Given this list of marker genes SCAI, HCAR1, G6PC2, ZNF417, CALM2, THAP2, FAM151B, MOSPD3, HAPLN1, CHP1, EGF, ZDHHC17, SSBP1, USF3, CAPN6, TIMP3, GAP43, TBL1XR1, UBE2W, AAK1, TSHZ2, SERTAD2, TMEM170B, SAMD12, RAB3GAP2, DGKI, ALG10 (ALG10 alpha-1,2-glucosyltransferase), DGKH, NFX1, URI1, MBTD1, FAM168A, GALNT10, SESTD1, CCDC34 (NCBI Gene Id 91057), HLCS, USP33, MAP2K1, CLVS1, JADE1, HACD1, TCF7L2, FCGR3B, ZC3H6, RGL1, YWHAQ, HMGN3, CCDC85C, GSPT1, LAMA4, FAM221A, KDM7A, GYS2, FRMD6, BBS10, PROK2, HCN3, CPED1, ANKS1B (ankyrin repeat and sterile alpha motif domain containing 1B), AIPL1, RLIG1, MYEF2, SETBP1, GIPC2, BLOC1S6, ITGA2, CHD3, OR12D3, FRMPD4, SPTLC3, CFAP91, AMPD3, AMD1, CLK4, STKLD1, BAG4, ARHGAP5, TIAL1, MYCT1, RIMOC1, AHCTF1, EVI2B, GALNT3, BLZF1, SGCD, APOBEC3A, PDCD4, HACD3, SNAI2, PPFIA2, IL5RA, ARHGAP36, ZNF395, RIMKLB, CAMK2D, TRPS1, ATP5MC3, here is a description of the gene set: from publication Chen Y, Wang X (PMID 31504780) studied in species Homo sapiens Genes predicted to be targets of miRBase v22 microRNA hsa-miR-890 in miRDB v6.0 with MirTarget v4 prediction scores > 80 (high confidence targets). Human Gene Set: MIR890